The following is a description of a gene set: Lymph node T cells isolated from Ezh2fl/fl or Ezh2 deficient mice Human Gene Set: GSE1566_WT_VS_EZH2_KO_LN_TCELL_UP studied in species Homo sapiens from publication Su IH, Dobenecker MW, Dickinson E, Oser M, Basavaraj A, Marqueron R, Viale A, Reinberg D, Wülfing C, Tarakhovsky A (PMID 15882624) Genes up-regulated in lymph node T cells: wildtype versus EZH2 knockout., and this is the list of marker genes: LINC00518, CTLA4, CFAP410, C1R, ETV5, ASIC1, ART4, ABHD17AP4, APCDD1, BATF2, MCEMP1, CASP4, GARIN3 (golgi associated RAB2 interactor family member 3), CLEC4F, CSNK2A2 (casein kinase 2 alpha 2), PRR30, KNOP1, DNAJB2, CCDC61, DLGAP2, FAM95B1, EPB41L5, CYP4F3, BMF, AKT1S1, CELSR1, C1QTNF1, EFCC1 (NCBI Gene Id 79825), ANXA2P2, CCDC178, ALG8, ADARB1, COL9A2, SDHAF3, CC2D1A, CORO1C, CCND3, ELOVL1, ANKH, COPE, COL4A2, ASPRV1, CDH3, EFHD1, CNN2, MFSD12, DNAJC22, DRD4, DIMT1, DNAJB8, DLGAP3, RPP38-DT, CTCFL, CD226, DIPK1C, TMEM255A, CYP1B1, METTL24, CRYBB2, CMA1, NELFB, COX7C, CALHM6 (calcium homeostasis modulator family member 6), C16orf54, BOC, CST1, CEP131, CTSF, BMP8A (bone morphogenetic protein 8a), ENOX2, ARHGAP33, DES, DDX51, C1orf131, ATP5IF1, CSPP1, ACVR1, ARL4A, CASP8AP2, ADH4 (NCBI Gene Id 127), BHMT, AHCYL1, ARV1, CCL19, LINC02868, FAM221A, CRIM1 (cysteine rich transmembrane BMP regulator 1), ANKK1, COTL1 (NCBI Gene Id 90755), DQX1, CDC25A, DNAJC5B, SAXO2, ATG3, DIPK2A, CHORDC1, COLEC11, CALR3, COQ10A, DNAJC1, CYP4F12, CHADL, CNKSR3, C1S, CTSB, ASAP3, BAHCC1, CMAHP, CD1A, ATP5PF, CAMSAP1, BOD1, TRABD2A, ATP6V1F, FDCSP, RHEX (regulator of hemoglobinization and erythroid cell expansion), COL16A1, DHRS7C, CCDC134, FAM90A1, CAMK2A, BTNL9, ADAM10, ENPP5, CIBAR2, CLN3, CCDC42, AMZ2, MINDY2, ADAMTS17, EVC2, AMTN, AKAP12, CMTM2, CLXN, CXCL11, C11orf42, DDX31, COBL, ABCD4, ADCY10, EDA, CNGA2, CSGALNACT1, CD200R1, LINC02897, DAP3, DSTNP2, COPZ2, EBF1, ALDH16A1, APOD, ELANE, CBFA2T3, MYRFL, AHSP, DGCR2, AMIGO2, ASIC4, CIMIP5, B3GALT2, CCDC54, CSF3R, ZFHX3, CBX8, APOC1, ARMC7, C1RL, CALML6, CDX2, EPC2, EID1, ARMCX1, DDX25, DGKK, C15orf32, ALKBH8, TEKTIP1, CKS1BP6, ANKRD30B, ABHD14B, DPT, CIAO2A, DNAJB11, EIF4EBP2, CTSD, DTD1, ADM2, ATIC, CEP250, EME1 (NCBI Gene Id 146956), SPATA6L, CACNA2D1, CDH12, C1QTNF2, EPHA4, CDHR5